The following is a description of a gene set: species: Homo sapiens Any process that activates or increases the frequency, rate or extent of the directed movement of organic acids into, out of or within a cell, or between cells, by means of some agent such as a transporter or pore. Human Gene Set: GOBP_POSITIVE_REGULATION_OF_ORGANIC_ACID_TRANSPORT, and this is the list of marker genes: PLA2G3, KMO, RAB3GAP1, PTGES, OXT, ACSL1, SLC7A5, TNFRSF11A, PLA2G10, P2RX7, ACE2, NTSR1, ABAT, P2RX4, SLC17A8, PSEN1 (NCBI Gene Id 5663), ITGB1, AVPR1B, AVP, EDN1, GABBR1, SLC12A2, CLTRN, ERFE, STXBP1, PLA2G4A, CYP4A11 (cytochrome P450 family 4 subfamily A member 11), ACSL5, MIF, FABP3, SYT4, DTNBP1, TNFSF11, ADORA2A, AVPR1A, ARL6IP1, IL1B, PLA2R1, TRH, ABCB11, SLC38A3, CYP4F2